The following is a description of a gene set: species: Homo sapiens from publication Chen Y, Wang X (PMID 31504780) Human Gene Set: MIR548T_5P Genes predicted to be targets of miRBase v22 microRNA hsa-miR-548t-5p in miRDB v6.0 with MirTarget v4 prediction scores > 80 (high confidence targets)., and this is the list of marker genes: RPS6KA5, PPP1R15B, TAOK1, CPNE8, GRM5, EIF4A1, GPD1L, DGKH, USP3, PHTF2, FZD2, EREG, TMEM170A, ZBTB7A, OSBPL8, RBMX, SOBP (NCBI Gene Id 654119), EPB41L5, MTF2, NAIF1, NFXL1, RANBP3, CEBPZOS, TGDS, WDR26, ERBIN, CLHC1, ZNF850, ZDHHC17, LRP1B (LDL receptor related protein 1B), ZNF217, CXCL5, PTPRJ, C11orf96, CETN3 (centrin 3), HSFY1, MYCN, TENM1, LRAT, SLC38A2, SALL3, ADAM22, EPRS1, RBM44, PLAG1 (PLAG1 zinc finger), SNX9 (NCBI Gene Id 51429), BRWD1, GJA3, LMX1A, CSMD3, FLRT3, B4GALT5, MIER3 (NCBI Gene Id 166968), PRKACB, CNTLN, RPS6KA3, NR4A3, ADGRB3, TRIM33, SERP1, PRKAR2B (protein kinase cAMP-dependent type II regulatory subunit beta), NAPB, DSCC1, ZNF711, ADAMTS9, APPL1, CITED2, CREB5 (cAMP responsive element binding protein 5), STK17B, SMARCA5, CRIM1, PKN2, LRIG1, MARCHF5, CXCL11, AQP4, ZEB2, USP21, NCAPG2, NEDD4, ARHGAP1, ZNF318, UTP25, MAPK1, C1orf162, SUZ12, ZNF106, SGPL1, GIPC2, GCOM1, ZNF234, TMEM128, GUCY1A2, LCOR, EXOC5, TENM4, IKZF2, ERO1A, PBRM1, ETF1, STX11, PPP6R3, PAPOLA, HS2ST1 (NCBI Gene Id 9653), TOX, CCDC152, GRIP1, CDC37L1, POLR2M, XRN1, ZNF737, ANKRD17, TMEM127, PLGLB2, DESI2, TMEM170B, SLC24A4, RAB27B, SS18, N4BP2, ATG16L1, ACER3, DCK, PPARG, SLC4A7 (solute carrier family 4 member 7), MITD1, DPY19L1, SAR1B, DPY19L4, GDA, HNF1A, NCKAP5, UBR3, SPAG9, WASF3, RNF212B, CLOCK, IGSF10, USP31, CHIC1, PTGR2, MAP3K2, FBXO22, MICU3 (NCBI Gene Id 286097), SLC2A13, RALGAPB, LEF1, TMCC1, MDGA2, SET, MTMR10, ABCA8, NTNG1, DENND4A, A1CF, HAUS2, TCEA1, ZC3H12C, TBCEL, MSI2, CADM2, RAPGEF1, USP28, DOCK4, PHLPP2, MYT1L, ATF2, BMP2, ZNF704, BICC1, FAT2, CAMK2D, RNLS, GLIS3, SOS1, CLXN, CTNNB1, PAK3, NABP1, CCSER1, SERTAD2, MAP4K5, PHC3, ARGFX, ZFHX4, NCOA1, ARIH1, B4GALT6, ARIH2, MARCKSL1, NFKB1, KRAS, EPHA5, LMAN1, SGMS2, R3HDM4, KIF21A, SCN2A, TRIM2, AP1S2, SMG1, MAP3K20, EXOC6, CHRAC1, YY1, MOB1B, INTS5, POU2F1, YPEL1, AICDA, AMER2, BCL2L11, PPP3CA, DYNC1LI2 (NCBI Gene Id 1783), CACNA2D1, KATNAL1, ECE1, LRRN1, ZFAT, FADS1, DLEC1, ZMYND11, GPN3, PTH, STXBP5, ANAPC11, RNF38 (NCBI Gene Id 64796), CEP44, NDST3, DTX4, NEO1, PSMA8, PPARA, UBR5, TOPORS, FOXG1, SGPP2, SYT16, UBE2K, BCAT1, RASGEF1A, SKIL, REEP3, CMBL, PPP2R2A, ITGB8 (NCBI Gene Id 3696), LEPROTL1, USP15, PGAP1, LPGAT1, BMPR2, RBMXL1, SUCO (NCBI Gene Id 51430), SPOPL, DCUN1D5, POU5F1B, SH3BP4, SLC6A6, ATAD2, HAS2 (NCBI Gene Id 3037), OLAH, TMTC3, CPEB4, KMT2A, ZCCHC8, ZNF484, OTOGL, ANO5, AQP3, CD2AP, KPNA3, TDP1, MAP4K3 (mitogen-activated protein kinase kinase kinase kinase 3), ZBTB41, HOXD13, APPBP2, SPOCK1, BPNT2, FUBP1, AGFG1, CHD1, MRPS25, MRTFB, HNRNPDL (NCBI Gene Id 9987), SLC4A4, ATXN1, RABGAP1L, USP46, ADD1, IPPK, PMP22, SMIM21, ST13, OTUD4 (OTU deubiquitinase 4), ADO, PIK3C2A, RAB5C, SSX2IP, STIM2, MFAP3L, PTBP3, THAP1, PACC1, BTG1, BRWD3, NRIP1, TPD52, KLHL23, IGF1R, MBOAT2, GPR137C, LIN7C, PCDHB7, ZNF367, HDAC9, MFSD5, HDX, ZNF493, PITPNA, KIF5C, ZNF99, ITGB1, NCBP2, CFL2, ZNF652, ARHGAP12 (NCBI Gene Id 94134), POU5F1, RYK, PDIK1L, YTHDC1, PDE4D, ZC3H6, OIP5, CDH1, RAB22A, ADAMTS4, YIPF2, ARID4B, RLIM, PAG1, POGZ, PHIP, HNRNPL, TCF4, STRN3, FOXL1, ERLIN2, ZFP36L2, CAPZA2, MECP2, KDM5B, RAB3D, PLGLB1, FEZ2, NCAM1, SMOC1, SGTB, RBBP7, GNG10, VEZF1, RYBP, GPD2, ASB4, CHST9, YES1, OSBPL5, FAM199X, SPOCK3, DGAT2 (diacylglycerol O-acyltransferase 2), TNRC6B, ZDHHC21, VPS29, PEX5L, PAIP1, UBE2Q2, C2orf69, ADARB1, UBE2D3, CLIP4, HSFY2 (NCBI Gene Id 92276), OPRM1, DPYSL2, RRAS2, TXN, MRPL19, AFDN, SGIP1, SLAIN2, FGF23, NAALAD2, DPP8, STK35, UBE3C, PCDH20, GPC6, CDH6, SMIM15, COL3A1, SNTB2, SGCZ, ITGA2, KPNA2, PLG, PTPN2, PPM1G, FRMD4A, TMEM131L, KLF9, BBX, PARP12, B3GALT2, R3HDM1, CREB1, ZNF451, TNS1, TMEM182 (transmembrane protein 182), GAB1, TP63, TBC1D8B, EPHA7, PLOD1, RNF217, TRPS1